Given this list of marker genes SDHD, FTL, SDHC, SDHA, ASAH1, SDHAF2, here is a description of the gene set: Human Gene Set: HP_LOSS_OF_VOICE studied in species Homo sapiens Loss of voice